The following is a description of a gene set: A condition caused by a deficiency of parathyroid hormone characterized by hypocalcemia and hyperphosphatemia. Human Gene Set: HP_HYPOPARATHYROIDISM studied in species Homo sapiens Hypoparathyroidism, and this is the list of marker genes: KMT2D, GATA3, SEC24C, MT-TL1, TBX2, LIG4 (NCBI Gene Id 3981), DGCR8, ESS2, ARVCF, HBB, MT-ND1, MT-TH, IRX5, PTH, MT-ND5, MT-ATP8, DGCR6, PTH1R, MT-ND4, RRM2B, FAM111A, MT-ND6, TBCE, TBX1, MT-TS2, RREB1, GCM2, GP1BB, MT-TW, UFD1, ATP7B, MT-CO3, AIRE, COL4A5, HADHB, MT-CO2, MPV17, MT-CO1, DGCR2, NKX2-1, KDM6A, NSUN2, JMJD1C, CHD7, MT-TF, HADHA, HIRA, MT-TQ, COMT, PIGT